The following is a description of a gene set: A segmental pattern of demyelination and regeneration (remyelination) affecting peripheral nerves. Human Gene Set: HP_SEGMENTAL_PERIPHERAL_DEMYELINATION_REMYELINATION Segmental peripheral demyelination/remyelination species: Homo sapiens, and this is the list of marker genes: SBF2, PMP22, MPZ, MT-TW (mitochondrially encoded tRNA-Trp (UGA/G)), MT-TL1, MT-ND6, MT-ND5, MT-TK, MT-TV, PRX, MT-ND1, MT-ND4, LITAF, MT-ATP6, NEFL, NDRG1, MT-ND2, MT-ND3, DNM2, GBF1, EGR2, PRPS1